Given this list of marker genes NANS, SPDL1, GET1 (guided entry of tail-anchored proteins factor 1), TBC1D9, PLK4, KIF11, PSIP1, CDC123, IRF1, PDSS1, EIF4A2, USP22, PPA1, PSTPIP2, PRKACB, FNBP1L, ACTL6A (NCBI Gene Id 9178), GCLC, HMGN1, SCRIB, ACO1, SMC2, SENP5, NCAPH, CENPU, NDST2, RAD51C (RAD51 paralog C), C1orf174, NEAT1, EPM2AIP1, ADARB1, PRUNE1, SMCO4, JAG1, NDUFB4, CITED2, PKP4, CCDC51, DDX1, GTSE1, TACC3, MIA, TBC1D4 (NCBI Gene Id 9882), OAZ2 (ornithine decarboxylase antizyme 2, NCBI Gene Id 4947), UBE4B, ARCN1, ARFGAP3, DDHD2, RAB27A, FAM53C, HIVEP3, GLYR1, TMEFF1, RAB14, ADI1, CENPA, NDC1, TOP2A, SEC24B, DNAJB4, IL15, C1GALT1C1, BMP6, RBMX, KCTD12, B3GNT2, CCDC88A, NSDHL, RFC3, E2F8, PAXIP1, SEPHS1, MEX3D, LSM5, RGS2, POLR2C, BIK, PCMTD2, EIF4A1, COL4A2, PRCC, GNA11, GALNT1, DYRK4, NNT, POLQ (NCBI Gene Id 29043), CPM, PCNP, UFC1 (ubiquitin-fold modifier conjugating enzyme 1), VCAN, ECT2, IGF2R, KIF15, RTF1, BIRC5, ABHD3, SEMA4C, KIF22, ZNF195, DDB1, LMNB1, COA1, U2AF1, KCTD3, ARRB2, HMGB2, RNFT2, SLC25A20, SKP2, SEMA3A, GBP2, KIF14, NREP, KLHDC3, KIF2C, HIP1, CDK1, MFAP1, TUBB4B, FAT4, RPAP3, APC, RUNX1, MRTFB, ARHGEF7, MRS2, ERAP2, CKS1B, EVI5, RACGAP1, SNRNP27, API5, BCL6, ZC3H7A, IDO1, CPA4, AURKB (NCBI Gene Id 9212), SPCS3, CBX1, GRIN2C, HMG20A, DOLPP1, CCT6A, FBXW11, IRF8, ZNF184 (NCBI Gene Id 7738), CKAP5, YTHDC2, ACTR6, FGD6, RBL2, TNFAIP1, LRRC8D, BTN2A2, TMEM165, PPP1CB, KHK, ABCC5, CPSF6, HEYL, ATXN10, DDX5, RBBP7, RB1, TRIB2, TRAK2, AHCYL2, CLP1, HELZ, CCNT2, PLAAT4, SHCBP1, RANBP6, PPP3CA, USP46, DNAJB1, MEGF6, MCTP1, DYNC1I2, RPA1, SEC24C, GALNT10 (polypeptide N-acetylgalactosaminyltransferase 10), MLLT11, PCDH7, AKAP11, EMD, IFT25, EIF3B, CSF2RB, HJURP, ZNF280D (NCBI Gene Id 54816), YWHAZ, GCLM, CTR9, CENPF, POLR3K, CTSC, FDPS, TESK2, here is a description of the gene set: Genes down-regulated in CD4 T cells over-expressing FOXP3 and PPARg1 isoform of PPARG: untreated versus GW1929. species: Homo sapiens from publication Cipolletta D, Feuerer M, Li A, Kamei N, Lee J, Shoelson SE, Benoist C, Mathis D (PMID 22722857) Pioglitazone treatment of CD4+FoxP3- T cells transduced with Pparg and Foxp3 up-regulated a set of genes whose products have been implicated in lipid metabolism pathways. To verify the specificity of this treatment, we performed microarray analysis on Foxp3+Pparg1-transduced CD4+FoxP3- T cells after treatment with other PPARg agonists such as Rosiglitazone (TZD) and GW1929 (non-TZD). Human Gene Set: GSE37534_UNTREATED_VS_GW1929_TREATED_CD4_TCELL_PPARG1_AND_FOXP3_TRASDUCED_DN